Given this list of marker genes NME3, NME9, NME2P1, AK3, NME5, CAD, NME4, NME7, UCK1, NME1 (NCBI Gene Id 7794), UCK2, UCKL1, CTPS2, ENTPD7, ENTPD4, NME6, CTPS1, NME2, here is a description of the gene set: studied in species Homo sapiens Human Gene Set: GOBP_PYRIMIDINE_RIBONUCLEOSIDE_TRIPHOSPHATE_METABOLIC_PROCESS The chemical reactions and pathways involving pyrimidine ribonucleoside triphosphate, a compound consisting of a pyrimidine base linked to a ribose sugar esterified with triphosphate on the sugar.